Given this list of marker genes GTPBP4, RAB1A, THAP6, MAP1LC3A, ZFPL1, DENR, MARCHF5, PIP4K2C, YTHDC1, ABL2, ANXA3, MAPKAPK3, SOWAHC, PPP1R10, MAIP1, EPHA2, SLC7A1, KMT2D, CSTB, ETF1, PTCD1, RELB, ATF5, RNF24, VAMP2, CDIP1, MMP12, NR4A1, KCMF1, TNFAIP3, ASB1, ADPRS, GLIPR1, HBS1L, TNIP1, CRTC2, DUSP11, AFF4, SMG5, TMEM256, PPP1R13B, HS6ST1, MAP4K4, DPH2, BLOC1S4, MEX3C, FAM83H, TMEM43, PPM1B, HSPA1B, IER5, COQ10B, YJU2, ALG11, ATOX1, JAM2, AMY2A, HLA-B, ARID5A, NFE2L2, WBP2, OVGP1, LZTS3, ZBTB2 (zinc finger and BTB domain containing 2), CD164L2, BTG3, ARHGEF3 (NCBI Gene Id 50650), CCNL1, CKAP4, SRC, SPRTN, FRS2, WDR70, SYCE3, CSRNP1, ZNF330, TACC2, ABT1, MRPS30, PHLDB1, MAFK, MED26, SMAD4, RHOF, IRS2, GNA13, C3orf38, CLDN12, ZBTB39, BCL2L1, DUSP1, ERCC1, LCAT, ZBTB21, PIM3, SQSTM1, SERTAD1, CD44, SHOC2, KMT5B, MRPL32, SLC7A5, PDRG1, ARF4, ADAM17, BCL2L11, AARS1, ZNF436, XPOT, ICAM1, RASSF8, C18orf21, NOCT, RTN4, SWAP70, PIK3R5, ZNF597, NFKBIB, TAX1BP1, IL1A, SUPT4H1, GNMT, CHTOP, CHD2, RPS19BP1, VPS37B, RAB20, CAMLG, TXNRD3, RPF1, BDP1, KLF6, ZNF830, IL2 (NCBI Gene Id 3558), ST3GAL1, NDFIP2 (NCBI Gene Id 54602), PPP1R15A, MAFF, MOAP1, NR4A3, FGF18, CEBPG, SGSM3, FAM181A, C3AR1, HSPA1A, SLC30A4, ZEB1, SURF6, SNORD104, YPEL5, UBE2D3, ADNP2, KLHL26 (NCBI Gene Id 55295), GADD45B, ZNF622, PSMD8, PAIP2, CWC25, TLK2, UBE2B (NCBI Gene Id 7320), FOXJ3, CCDC86, ETS2, POGK, ANXA5, ATF3, PTX3, AMZ2 (archaelysin family metallopeptidase 2), AMHR2, PDGFB, PTPN2, ZNF546, BASP1, FURIN, NDRG1, THUMPD1, NAT14, MLLT6, DUSP3, HNRNPDL, TOM1, DLGAP4, KLF16 (KLF transcription factor 16), ADM, ARPC5L, EAF2 (ELL associated factor 2), TBC1D12, TIMM10, FNDC3A, BIRC3, KLF7, CFL2, LAMTOR3, ATP6V1C1, RAB13, SAMD4A, EXTL3, EGR2, CD40, here is a description of the gene set: Genes up-regulated in memory CD8 T cells: wildtype versus TCF7 knockout. from publication Zhou X, Yu S, Zhao DM, Harty JT, Badovinac VP, Xue HH (PMID 20727791) TCF-1 is an HMG family transcription factor which is known to be activated by the canonical Wnt signaling pathway and modulated by other signals such as those derived from T cell receptor. We found that during CD8 T cell responses, TCF-1 deficiency impaired long-term maintenance of antigen-specific memory CD8 T cells. We used microarrays to detect gene expression changes in memory CD8 T cells caused by TCF-1 deficiency. Human Gene Set: GSE20754_WT_VS_TCF1_KO_MEMORY_CD8_TCELL_UP studied in species Homo sapiens